The following is a description of a gene set: species: Homo sapiens Genes up-regulated in T conv cells (2h): medium versus TNF. from publication Nagar M, Jacob-Hirsch J, Vernitsky H, Berkun Y, Ben-Horin S, Amariglio N, Bank I, Kloog Y, Rechavi G, Goldstein I (PMID 20181891) Human Gene Set: GSE18893_CTRL_VS_TNF_TREATED_TCONV_2H_UP Here we show that tumor necrosis factor (TNF) induced in human T-regulatory cells (Treg), as compared to conventional T cells (Tcon), a transcription program highly enriched for typical NF-κB target genes, such as: the cytokines LTA and TNF; the TNF-receptor super family members FAS, 4-1BB and OX-40; various anti-apoptotic genes; and other important immune-response genes. As an initial approach to examine the cellular program induced by TNF in Tregs versus Tcon cells, we employed microarray gene expression analysis at 2 and 24 hrs following TNF treatment., and this is the list of marker genes: PCDHGC4, ETHE1, SH3BGRL3, UBA1, BIN3, ST3GAL5, BLCAP, TMCO3, NDFIP1, NBEAL2, PRIMPOL (NCBI Gene Id 201973), RGS19, FMC1, STX19, ATP6V1E1, SMG8 (SMG8 nonsense mediated mRNA decay factor), TRIOBP, ORMDL1, DNAAF11, OSBPL2, LASP1, STRADB (STE20 related adaptor beta), ADK, TGDS, TMEM216, TFDP1, PAQR5, TANGO6 (transport and golgi organization 6 homolog), MYO1F, PARPBP, ZNF142, SYNE2, LDHC, LPGAT1, TBP (NCBI Gene Id 6908), CYSTM1 (cysteine rich transmembrane module containing 1), KRT33B, SMIM20, CAPZA3, NKIRAS2, SPMIP4 (sperm microtubule inner protein 4), ASNSD1, KIF5B (NCBI Gene Id 3830), HSD11B1, POLR2J, GALNT3, HDAC10, DMWD, GLYR1, ARPC3, IFITM3, ATP2B3, GRHPR, ENKD1, TNPO1, COQ4, RNF181, APIP, NSUN4, PAIP1, ITGA2, RAB5A, TPD52L2, DEF6, C15orf48 (chromosome 15 open reading frame 48), KIF21B, DDX31, C2orf68, ACTR3, RARS1, ADAM10, DHDDS, ATAD2B, ADPRH, TINAGL1, SEMA7A, RAP2C, KCNAB2 (potassium voltage-gated channel subfamily A regulatory beta subunit 2), RINL, NPLOC4, TMEM52, IST1, MPDU1, DBH, EFHD2, SYNE1, IRAK3, GMIP, DNMBP, MAPK1IP1L, CYBA (cytochrome b-245 alpha chain), EIF4A1 (eukaryotic translation initiation factor 4A1), C1D, ARHGAP1, DMPK, DHRS11, MTHFS, PLXNC1, RHOH, TMEM179B, PENK, TBC1D8 (TBC1 domain family member 8), ANKHD1, CHAC2, ACTN1, SLC16A3, GSDME, DAZAP2, SNRPC, ITK, ALS2CL, GYS1, ARAP3 (NCBI Gene Id 64411), MLX, MOSPD3, CD86, XKR8, SPG21, SPP1, ST3GAL2, THOC6, UGDH, VPS26C, SAMD9L, MORC3, RASA2, DYNLT1, TINF2, JDP2, GALC, GARIN3, PPP1R42, ATRN, BRD7, PSMB8, STAG2, IGSF11, KPNA4, EXOC3, PLCL2, CAAP1, ZNF143, SHLD1, MOCOS, RUFY1, PLCB3, MED30, NIPSNAP3A, MRPS11, GNPDA1, HAAO, G3BP2, PSMB9, SLC66A2, POMP, VPS26A, PDF, SLC5A11, RIOK1, ANKS1A, HLA-B, RAB11A, ACTRT1, MAP2K4, NRBP1, APH1B, SLC27A4, GPATCH8, PTP4A3, TRABD, GOT2 (NCBI Gene Id 2806), UBN1, ASPRV1, LCN12, PSMD10, ZNF830, ACVRL1, SEC22B (NCBI Gene Id 9554), SRP19, PADI4, LAMTOR3, PDZD8, CAPZB, EIF2AK1, COPG2, PPP6C, ECH1, HMGB2, YKT6, KATNA1, C16orf54, DEPDC1B, MON1B, KRT76, MED31, COA3, CENPJ, ATG16L2, CAB39L, CFAP119